Given this list of marker genes CLC, PF4, PIK3CG, PTCH1, DHH, CD1E, AZU1, DYRK2, PRKAA1, MTMR11 (myotubularin related protein 11), STAT2, HLF, TP63, PPBP, IFNAR1, GPR12, PRG2, UPK3A, ZNF117, CD8B, here is a description of the gene set: Genes down-regulated in bone marrow hematopoietic stem cells (HSC, CD34+) from patients with high risk of myelodysplastic syndrome (MDS) compared with healthy controls. from publication Hofmann WK, de Vos S, Komor M, Hoelzer D, Wachsman W, Koeffler HP (PMID 12411319) Human Gene Set: HOFMANN_MYELODYSPLASTIC_SYNDROM_HIGH_RISK_DN species: Homo sapiens Gene patterns of expression in purified CD34(+) bone marrow cells from 7 patients with low-risk myelodysplastic syndrome (MDS) and 4 patients with high-risk MDS were compared with expression data from CD34(+) bone marrow cells from 4 healthy control subjects. CD34(+) cells were isolated by magnetic cell separation, and high-density oligonucleotide microarray analysis was performed. For confirmation, the expression of selected genes was analyzed by real-time polymerase chain reaction. Class membership prediction analysis selected genes. Using the expression profile of these genes, we were able to discriminate patients with low-risk from patients with high-risk MDS and both patient groups from the control group by hierarchical clustering (Spearman confidence). The power of these genes was verified by applying the algorithm to an unknown test set containing expression data from 8 additional patients with MDS (3 at low risk, 5 at high risk). Patients at low risk could be distinguished from those at high risk by clustering analysis. In low-risk MDS, we found that the retinoic-acid-induced gene (RAI3), the radiation-inducible, immediate-early response gene (IEX1), and the stress-induced phosphoprotein 1 (STIP1) were down-regulated. These data suggest that CD34(+) cells from patients with low-risk MDS lack defensive proteins, resulting in their susceptibility to cell damage. In summary, we propose that gene expression profiling may have clinical relevance for risk evaluation in MDS at the time of initial diagnosis. Furthermore, this study provides evidence that in MDS, hematopoietic stem cells accumulate defects that prevent normal hematopoiesis.